The following is a description of a gene set: Genes positively differentially expressed in cell type: NK cell upon treatment with cytokine: TNF-α in mouse lymph nodes in vivo. from publication Cui A, Huang T, Li S, Ma A, Pérez JL, Sander C, Keskin DB, Wu CJ, Fraenkel E, Hacohen N (PMID 38057668) species: Mus musculus Cytokines mediate cell-cell communication in the immune system and represent important therapeutic targets. A myriad of studies have highlighted their central role in immune function, yet we lack a global view of the cellular responses of each immune cell type to each cytokine. To address this gap, the authors created the Immune Dictionary, a compendium of single-cell transcriptomic profiles of more than 17 immune cell types in response to each of 86 cytokines (>1,400 cytokine-cell type combinations) in mouse lymph nodes in vivo. A cytokine-centric view of the dictionary revealed that most cytokines induce highly cell-type-specific responses. For example, the inflammatory cytokine interleukin-1β induces distinct gene programmes in almost every cell type. A cell-type-centric view of the dictionary identified more than 66 cytokine-driven cellular polarization states across immune cell types, including previously uncharacterized states such as an interleukin-18-induced polyfunctional natural killer cell state. Mouse Gene Set: CUI_NK_CELL_TNFA_RESPONSE_UP, and this is the list of marker genes: Ikbke, Serpina3f, Acot9, Rnf19b, Birc3, Cd274, Serpina3g, Klhl9, Relb, Tnfrsf9, Il2ra, Sh3bgrl3, Dscam, Nfkb2, Edf1, Cish, Adprs, Eif5a, Stap1, Serpinb9, Gadd45b, Tnip1, Pim2, Bcl3, Ptp4a2, Sdhaf1 (NCBI Gene Id 68332), Pou2f2, Irf1, Mnt, Socs1 (NCBI Gene Id 12703), Gdpd5, Nfkbia, Gzmc, H2-K1, Gbp4, Ptpn22, Cyba, Il7r, Calr, Ltb, Prdx6, Itgb3, Cd83, Rpf2, Cd82, Bcl2l11, Bcl2a1d, Bcl2a1b, Tnfrsf18, Gbp5, Mndal, Ifi211, Fyb1, Jak3, Batf, Jaml, Mvp, Pdcd1lg2 (programmed cell death 1 ligand 2), Lcp1, Timm13, Klrb1b, Apobec3, Traf1, G3bp1, Hvcn1, B2m, Serpinb6b, Odc1, Tmem106b, Ahr (NCBI Gene Id 193333), Zmiz2, Limd2, Sec11c, Ly6e, Ap2a2, Ifngr1, Lilrb4b, P2ry10, Kit, Litaf, Zdhhc21, Icam1, Ppp1r16a, Ehd1, Iars1, Ccdc184, Nfkbie, Larp4, Cdc25a